The following is a description of a gene set: species: Mus musculus Mouse Gene Set: GOBP_REGULATION_OF_GLIOGENESIS Any process that modulates the frequency, rate or extent of gliogenesis, the formation of mature glia., and this is the list of marker genes: Dag1, Dicer1, Hes1, Ntrk3, Tnf, Ctnnb1, Drd3, Bmp4, Bag1, Tmem98, Trf, Hmga2, Sox11, Lingo1 (NCBI Gene Id 235402), Il6, Tnfrsf1b (NCBI Gene Id 21938), Etv5, Igf1, Clcn2, Pparg (peroxisome proliferator activated receptor gamma), Il33, Prpf19, Sirt2, F2, Rnf10, Casz1, Atoh1, Kdm4a, Olig2, Vegfc, Dlx2, Arrb2, Tert, Hes5, Prkch, Rela, Aspa, Nr1d1, Cers2, Idh2, Ptk2, Ufl1, Myc, Lin28a, Trp53, Gfap, Cysltr2, Atf5, Zcchc24, Daam2, Atxn1, Bin1, Fgfr3, Egr2, Lyn, Shh, Tgfb1, Mir23a, Il34, Ldlr, Plag1, Fas, Spint1, Ntf3, Hdac1, Ptprz1, Csf1r, Ntn1, Il6st, Ppp1cc, Dlx1 (NCBI Gene Id 13390), Mycn, Zfp365, Mdk, Id2, Synj1, Cxcr4, Mir219a-1, Nr2e1, Mtor, Cysltr1, Gpr37l1, Mfn2, Dab1, Vim (NCBI Gene Id 22352), Il1b, Actr3, Mag, Ascl2, Nkx2-2os, Flt1, Tspo, Trp73 (NCBI Gene Id 22062), Nrg1, Abcc8, Cdkn2b, Gsx2, Sox10, Dll3, Nf1, Id4, Dusp10, Myrf, Myb, Notch1, Tenm4 (teneurin transmembrane protein 4), Mbd1, Enpp2, Rb1, Serpine2, Bmp2, Sox8, Nkx6-2, Tlr2, Hdac2, Kras, Ski (NCBI Gene Id 99956, ski sarcoma viral oncogene homolog (avian)), Nkx2-2, Gjc2, Zfp488, Qki, Clcf1, Lta, Nkx6-1, Nf2 (NCBI Gene Id 18016), Ptpra, Lrp2, Adcyap1, Rnf112, Trem2, Mecp2, Ptn (pleiotrophin), Pitx3, Prmt5, Ezh2 (NCBI Gene Id 14056), Lif, Egfr, Mir219a-2, Rtn4, Prkci, E2f1, Nog, Slc7a5, Rheb